Given this list of marker genes NCAPG, CSE1L, TOP2A, MCM6, RRM2, PPIF, HBB, PRC1, LAT, RAD51AP1, CDK1, DLGAP5, MINPP1, GINS1, PCNA, DTL, BIRC5, CHEK1, NUSAP1, RNASEH2A, CDC20 (cell division cycle 20), HAT1, HBD, GZMB, CDC25A, ATP5MC3, KIF11, MSH2, BUB1, PCLAF, DUT, GGH, OIP5, AQP3, RACGAP1, FABP5, MCM5, CEP55, VRK1, GINS2, RRM1, SNRNP25, TRIP13, RFC3, KIF2C, LEPR, CD36, MCM4, XK, KIF18B, MCM2, SMC2, COTL1, SLC7A5, POLE2, KIF15, MELK, CCNA2, CSF2RB, CCNB2, RFC4, APOBEC3B, CDC6, NPM3, TYMS, BUB1B, NDC80, MCM10, FEN1, GMNN, CDKN3, CCNE2, CENPU, CDC45, CENPM, PRG2, HBG1, CCNE1, CPA3, CKS1B, TK1, MAD2L1, DSCC1, DHFR, SAC3D1, NUP85, ZWINT, AMMECR1, VDAC3, here is a description of the gene set: from publication Graham SM, Vass JK, Holyoake TL, Graham GJ (PMID 17717066) Quiescent and dividing hemopoietic stem cells (HSC) display marked differences in their ability to move between the peripheral circulation and the bone marrow. Specifically, long-term engraftment potential predominantly resides in the quiescent HSC subfraction, and G-CSF mobilization results in the preferential accumulation of quiescent HSC in the periphery. In contrast, stem cells from chronic myeloid leukemia (CML) patients display a constitutive presence in the circulation. To understand the molecular basis for this, we have used microarray technology to analyze the transcriptional differences between dividing and quiescent, normal, and CML-derived CD34+ cells. Our data show a remarkable transcriptional similarity between normal and CML dividing cells, suggesting that the effects of BCR-ABL on the CD34+ cell transcriptome are more limited than previously thought. In addition, we show that quiescent CML cells are more similar to their dividing counterparts than quiescent normal cells are to theirs. We also show these transcriptional differences to be reflected in the altered proliferative activity of normal and CML CD34+ cells. Of the most interest is that the major class of genes that is more abundant in the quiescent cells compared with the dividing cells encodes members of the chemokine family. We propose a role for chemokines expressed by quiescent HSC in the orchestration of CD34+ cell mobilization. Disclosure of potential conflicts of interest is found at the end of this article. Genes down-regulated in quiescent vs dividing CD34+ cells isolated from peripheral blood of normal donors. Human Gene Set: GRAHAM_NORMAL_QUIESCENT_VS_NORMAL_DIVIDING_DN studied in species Homo sapiens